Given this list of marker genes SPCS2, TRA2B, EPRS1, RBMX, XPO1, KHDRBS1, CCDC59, PTMA, SMNDC1, RWDD1, CPSF6, TOPBP1, HNRNPU, ZNF146, PPIH, PAPOLA, BRD8, SSB, ZNF22, PABPN1, MAPK1IP1L, SRP72, HNRNPA1, SRP19, COPB1, ZC3H15, TARDBP, DENR, DIMT1, EXOSC8, BCAS2 (NCBI Gene Id 10286), MPHOSPH10, FUS, PPIA, PSMC6, SUMO2, MTDH, SLC7A5P1, DDX50, MRPS10, IFT25, HNRNPH3 (NCBI Gene Id 3189), SYNCRIP, EIF3A, MRPL9, DDX47, INTS8, HNRNPR, HNRNPA3P1, RBM15, PDS5A, here is a description of the gene set: species: Homo sapiens Neighborhood of DENR Human Gene Set: GNF2_DENR Neighborhood of DENR density-regulated protein in the GNF2 expression compendium